Given this list of marker genes TUBA1A, GABRA1, SCN9A, GABRG2, DCC, PCDH19, TUBB3, NTN1, KDM4B, SCN1B, SCN1A (sodium voltage-gated channel alpha subunit 1), DPYSL5, DNAL4, RAD51, SCN2A, MACF1, here is a description of the gene set: Structural abnormality of the hippocampus related to defective development. species: Homo sapiens Human Gene Set: HP_DYSGENESIS_OF_THE_HIPPOCAMPUS Dysgenesis of the hippocampus